The following is a description of a gene set: Human Gene Set: HP_GINGIVAL_BLEEDING Gingival bleeding Hemorrhage affecting the gingiva. species: Homo sapiens, and this is the list of marker genes: RACGAP1, BLOC1S3 (biogenesis of lysosomal organelles complex 1 subunit 3), F8 (coagulation factor VIII), C1R, STAT5B, FGB, LYST, HPS1, IRF2BP2, PML, BCOR, TERC, F13B, FYB1, IL18BP, MCFD2, F7, TERT, GP1BA, PRF1, TBL1XR1 (NCBI Gene Id 81612), IFNG, FGG, MYD88, NPM1, PLCG1, ITGA2B (NCBI Gene Id 3674), LMAN1, HPS3 (HPS3 biogenesis of lysosomal organelles complex 2 subunit 1), NUMA1, ITGB3, WIPF1, BLOC1S5, GP1BB, SBDS, F5 (NCBI Gene Id 98271), SERPINF2, PRKAR1A, GP9, FIP1L1, WAS, F10, GALE, FCGR2C, NABP1, F2, ADAMTS2, CAT, STAT3, F13A1, SCARB2, GBA1, C1S, RARA, JAK2, KIF23, ZBTB16, FGA, ELMO2